The following is a description of a gene set: We demonstrate that the G protein Gi3 is the cellular target of the adenosine A3 receptor (A3R). By using a cell permeable peptide comprising the C-terminal end of Gαi3 fused to an importation sequence (ALL1) as a selective inhibitor of Gi3 signaling, we show that by coupling to Gi3, the A3R stimulates multiple signaling pathways in human mast cells, leading to upregulation of cytokines, chemokines and growth factors.Following contact with activated T cell membranes, endogenous adenosine binds to and activates the A3R, resulting in Gi3-mediated signaling. Specifically, the majority of ERK1/2 signaling initiated by contact with activated T cell membranes, is mediated by Gi3, giving rise to ALL1-inhibitable cellular responses. These results unveil the physiological GPCR that couples to Gi3 and establish the important role played by this G-protein in inflammatory conditions that involve adenosine-activated mast cells. We used microarrays to detail the effect of ALL1 on gene expression of HMC-1 cells activated directly by the A3 receptor, or by contact with activated T cell membranes. Genes down-regulated in HMC-1 (mast leukemia) cells: untreated versus Cl-IB-MECA. studied in species Homo sapiens from publication Baram D, Dekel O, Mekori YA, Sagi-Eisenberg R (PMID 20190146) Human Gene Set: GSE19888_CTRL_VS_A3R_ACTIVATION_MAST_CELL_DN, and this is the list of marker genes: PAH, NOVA1, NKX6-2, PTGER1, FAM174B, CNGA1, TMEM100, ODF1, CD28, NCK1, KLHL35, ERAS, THOC6, CYP3A43, SERPINA7, GPR151, CRISPLD1, IGF1, TEX56P, VSTM4, KLF6, ADPRHL1, CCDC70 (NCBI Gene Id 83446), STK31, INPP1, AQP2, PPP1R15B (protein phosphatase 1 regulatory subunit 15B), DQX1, DMC1, MYH10, ERBB4, GDE1, CST8, LYZL4, PRTN3, TVP23A, EFHD1, ARHGEF10, H3C7, TMEM236, SCML4, SEC23A, RIPOR2, NOTCH2, SAMSN1, XK, AKR1C3, SYTL3, VN1R5, OIT3, C12orf75, PNLIPRP2, ATG4D, PDHA2, COMMD3, IL1RL1, CCDC198, MUC5B, PENK, HAS1 (hyaluronan synthase 1), ZNF354C, FGA, LEMD1, HAND2 (heart and neural crest derivatives expressed 2), LKAAEAR1, SLC10A2, PRR15, NRG2, CCDC7, MIP, DPM3, APOA4, CRH, NDRG4, GALNT14, NRGN, RPS27L, PTAFR, LURAP1L, EIF3M, RAMP1, TSPAN8, SHCBP1L, NECTIN3, SPOCK2, PILRA, SPATA46, TTLL13, SMAD9, CCL17, MYL4, IQCF5, PRDM16-DT, TTL, PSD2, AGTR1, VIT, KLHL9, TAFA1, ZMYND10, RNF182, FSCN3, ZKSCAN8P1, ST13, NLRP14, CHAD, SLC17A6, LGI4, SEMA3C, ERRFI1, CMBL, TMEM256, NLRP4, TNFSF11, GKN2, TRHR, GALNT1, MAGI3, MGME1, SP5, BATF3, NDN (necdin, MAGE family member), RCN2, TXNDC8, LCN12, LHX9, CYP4F12, SLC30A8, INSYN2B, LYSMD2, HMX3, CNIH1, S1PR1, SSTR3, C2orf88, C19orf73, CAPZA3, FLYWCH2, GJA8, CDON, OCEL1, KHDC3L, GCNT7, RP1L1, SH2D1A, MYF5, PROC, GSTK1, APOBEC3B, POLH (DNA polymerase eta), PKIG, ARIH2OS (ARIH2 opposite strand lncRNA), TERF2IP, PDE6C, FEM1C, PDCD4, RIMKLA (NCBI Gene Id 284716), DIO1, SLC35E4, CALML4, SRGAP1, ACKR2, OLFM4, DNAI3, GGACT, IL4, CABP5 (calcium binding protein 5), SCN10A, COL6A5, C12orf42 (NCBI Gene Id 374470), KDELR2, SLC25A31, DYNC1I1, LRRC74A, NSG2, PLXDC2, TRIM45, RXFP1, WNT11, KLF2, MATCAP1, ATP6V0E1, PTTG1IP, SAXO4, IL17D, CA5B, SPMAP2, PNMA8A, ZSWIM3, SEC62, ACTR8, TWIST1, HES5, PILRB, DPYSL2 (dihydropyrimidinase like 2), GPATCH3, TNP1, SPOUT1, FNDC1